Given this list of marker genes TTLL5 (tubulin tyrosine ligase like 5), TTLL13, TTLL6, TTLL11, TTLL9, TTLL7, TTLL1, here is a description of the gene set: studied in species Homo sapiens Catalytic reaction:(L-glutamyl)n-L-gamma-glutamyl-L-glutamyl- + ATP + L-glutamate = (L-glutamyl)n+1-L-gamma-glutamyl-L-glutamyl- + ADP + H+ + phosphate. Human Gene Set: GOMF_PROTEIN_GLUTAMIC_ACID_LIGASE_ACTIVITY_ELONGATING